Given this list of marker genes CDKN1A, ORC1, MBTPS2, TAOK3, PABIR1, CHEK1, RINT1, TAOK1, CLSPN, HUS1, ZNF830, CDC14B, NBN, CDC6, BLM, NABP2, RAD50, INTS3, BRCC3, RAD17, BRCA1, RBBP8, MBTPS1, BRSK1, UIMC1, HUS1B, NOP53, FZR1, CDK1, ABRAXAS1, TICRR, NABP1 (NCBI Gene Id 64859), SYF2, FOXO4, MRE11, ATR, TAOK2, DTL, PLK1, INIP, ATM, MRNIP, DONSON, NAE1, IER3, CHFR, TOPBP1, ETAA1, CDK5RAP3, TRIM39, FOXN3, BABAM1, BABAM2, BARD1, here is a description of the gene set: species: Homo sapiens Human Gene Set: GOBP_MITOTIC_G2_M_TRANSITION_CHECKPOINT A cell cycle checkpoint that detects and negatively regulates progression from G2 to M phase as part of a mitotic cell cycle.